Given this list of marker genes TMEM43, BUB3, TNPO3, AHCY, LMNA, COL4A1, SYNE2, CEP57, COL6A3, MYH7, CAPN3, CAV3, TOR1AIP1, HNRNPA1, COL6A1, BUB1, PNKP, HNRNPDL (heterogeneous nuclear ribonucleoprotein D like), DMD, BAG3, NPPA, SGCA, GMPPB, CAVIN1, COL6A2, SGCB, SCN5A, TRIM32, GK, PIEZO2, B3GALNT2, B4GAT1, DPM3, DAG1, ITGA7, FKTN, LIPE, RYR1, ITGB4 (integrin subunit beta 4, NCBI Gene Id 3691), SGCD, RXYLT1, FRG1, POMT2, ACTA1, PLIN4, TRIP4, DNAJB6, NR0B1, JAG2, BVES, LAMA2, FKRP, SMCHD1, DPM1, TCAP, TRAPPC11, SYNE1, SELENON, EMD, LIMS2, BUB1B, POGLUT1, SGCG, POMK, PLEC, DYSF, POMGNT1, TRIP13, POMGNT2, ANO5, CHKB, TTN, POMT1 (protein O-mannosyltransferase 1), SIL1, CRYAB, FHL1, CRPPA, BET1, COL12A1, LARGE1, here is a description of the gene set: species: Homo sapiens Muscular dystrophy Human Gene Set: HP_MUSCULAR_DYSTROPHY The term dystrophy means abnormal growth. However, muscular dystrophy is used to describe primary myopathies with a genetic basis and a progressive course characterized by progressive skeletal muscle weakness and wasting, defects in muscle proteins, and histological features of muscle fiber degeneration (necrosis) and regeneration. If possible, it is preferred to use other HPO terms to describe the precise phenotypic abnormalities.